Given this list of marker genes DOCK8, CIR1, ZDHHC2, SMG9 (SMG9 nonsense mediated mRNA decay factor), IFI27, DENND2D, SARNP, MRTFB, RPUSD2, UQCC2, UFL1, NAT1, SYNJ2, TTF2 (transcription termination factor 2), GCNT1, MRPL23, SDF2L1, MIGA2, SMIM20 (small integral membrane protein 20), UQCR11, SH3BGRL, NDUFA12, AP1M1, SPICE1, VPS26C, HVCN1, ZNF207, CELF2, TBC1D10C, ATP5MF, NDUFB11, MBIP, ZBTB40, CDK2AP2, TRPM6, TRIP4, NDUFC2, ARHGAP15, INTS3, KCNC2, TMED3, TRMT112, TRAPPC1, MAST3, TMEM9B, AREG, C2CD3, ACAP1, ESM1, CIAO2B (NCBI Gene Id 51647), COMMD3, HMBS, CRIPT, PKNOX1, FAF1, CLIP1, PUS10, PHF14, AFG1L, FERRY3, DOCK2, S100A6, STXBP5, PURA, RHBDD1, CIBAR1, EMC2, GALM, NDUFB9, DNAJC3, DYNLT1, IKZF4, ABI2, PHACTR2, TMEM147, MRPL52, FCHO1, CTPS2, GMPPA, CCNQ, PSMB1, IL7R, ANXA1, LGALS1, CCDC91, MTCP1, ZC3H4 (zinc finger CCCH-type containing 4), PECR, CDK10, ZNF407, RPP40, SSR1, THOC7, TGFBRAP1, TASOR, ABCB1, GSPT2, GPATCH1, TMEM176B (transmembrane protein 176B), POMGNT1, DGCR8, PLSCR1, CXCR6, TMBIM4, GYG1, WDR33, PTPRCAP, NR2C2, TEP1, MBOAT1, CHM, SLC35G1, CASP1, RGS19, LAMTOR3, DXO, SLAMF6, CBFB, SBF2, ERCC1, ERLIN2, TXNL1, SOCS2, TMEM259, ITFG2, PNO1, POLR2H, TPP1, S100A13 (S100 calcium binding protein A13), RAD1, RFC4 (NCBI Gene Id 5984), NCF4, CCDC32, MTG1, RPA3 (NCBI Gene Id 6119), B3GALNT2, NAA38, ERMARD, OCRL (OCRL inositol polyphosphate-5-phosphatase), ALDH18A1, ATXN1, ZNF287, TM6SF1, PPFIBP1, RMDN1, NAA35, LARS2, LANCL3, ENTPD4, SEPTIN2 (NCBI Gene Id 4735), METTL5, FOXP3, USP45, GALNT4, KLHL9, EIF4EBP1, ADAM8, SYNGR2, RIC8A, CASP4 (caspase 4), CDPF1, INTS8, NDUFS7, MMUT, NARS2, ZNF692, THY1, PLPP5, RNF216, MYEF2, ZNF383, RAB39B, MRPL51, ACP3, PEX11A, SCAPER, TMEM184C, NFATC2, DCTN2, C5orf22, ARHGAP9, DNAJC15, MCM5, ZNF600, GTPBP2, IL1R1, CCNB1IP1, OAS1, APOOL, DPY19L4, KRCC1, CALCB, PREB, BABAM2, PUM2, ACACA, MRPL55 (NCBI Gene Id 128308), NIBAN3, GTPBP3, DNPH1, here is a description of the gene set: from publication Shinohara H, Behar M, Inoue K, Hiroshima M, Yasuda T, Nagashima T, Kimura S, Sanjo H, Maeda S, Yumoto N, Ki S, Akira S, Sako Y, Hoffmann A, Kurosaki T, Okada-Hatakeyama M (PMID 24833394) species: Homo sapiens The activation signaling of transcription factor nuclear factor-kB (NF-kB) plays central role for immune system. One of key kinase mediating this pathway is TAK1 in adaptive and innate immunity. However, role of TAK1 in B cell receptor signaling is still unclear. To know effects of TAK1-deletion on the gene expression induced by anti-IgM, we performed the time course analysis in comparison of wild type with TAK1-deleted splenic B cells. Genes up-regulated in B lymphocytes with MAP3K7 knockout: untreated versus anti IgM for 1h. Human Gene Set: GSE41176_UNSTIM_VS_ANTI_IGM_STIM_TAK1_KO_BCELL_1H_UP